Given this list of marker genes CISD2, PINK1, HK1, FAF2, OPTN, FKBP8, TOMM70, PRKN, CISD1, here is a description of the gene set: Pathway Definition from KEGG: PINK1 -> PRKN -> (CISD1,CISD2,FAF2,FKBP8,TOMM70,HK1) // OPTN* Human Gene Set: KEGG_MEDICUS_VARIANT_MUTATION_INACTIVATED_OPTN_TO_PINK_PARKIN_MEDIATED_AUTOPHAGOSOME_FORMATION Mutation-inactivated OPTN to PINK-Parkin-mediated autophagosome formation. Pathway ID: N01138. Pathway type: Variant. Pathway class: nt06464 Amyotrophic lateral sclerosis. species: Homo sapiens